Given this list of marker genes SLC44A2, SLC22A12, SLC30A1, SLC18A2, RHBG, SLC6A3, HEPH, SLC39A1, RSC1A1, SLC14A2, SLC6A15, SLC22A8, SLC6A14, SLC39A4, SLC6A5, SLC31A1, SLC22A5, SLC40A1, SLC22A15, SLC39A3, SLC13A3, SLC30A3, SLC6A13 (solute carrier family 6 member 13), SLC44A3 (solute carrier family 44 member 3), SLC39A14, SLC30A10, SLC2A13, SLC6A19, SLC6A18, SLC30A5, SLC47A1, SLC22A18, SLC39A8, SLC39A5, SLC14A1, SLC6A9, SLC16A8, SLC5A11, RUNX1, SLC22A4, SLC10A6, SLC13A4, SLC16A3, SLC13A5, SLC22A3, SLC6A1, SLC44A4, SLC44A5, SLC16A1, SLC22A11, SLC18A1, RHAG, SLC6A6, SLC13A2, SLC39A10, SLC39A7, SLC6A12, RHCG, SLC22A7, SLC22A6, SLC11A1, SLC41A1 (NCBI Gene Id 254428), SLC22A16, SLC41A2, SLC11A2, SLC6A2, SLC30A2, SLC30A8, SLC44A1, SLC6A20, CP, BSG, SLC39A6, SLC39A2, SLC22A2, SLC13A1, SLC16A7, EMB, SLC5A7, SLC22A1 (NCBI Gene Id 6580), SLC6A7, SLC5A3, SLC47A2, SLC6A11, here is a description of the gene set: Transport of bile salts and organic acids, metal ions and amine compounds studied in species Homo sapiens Human Gene Set: REACTOME_TRANSPORT_OF_BILE_SALTS_AND_ORGANIC_ACIDS_METAL_IONS_AND_AMINE_COMPOUNDS